Given this list of marker genes DPP4, FFAR1, SPCS2, ISL1, GIP, SEC11C, SPCS3, GATA4, PAX6, SPCS1, SEC11A, PCSK1, GPR119, here is a description of the gene set: part of: Incretin synthesis, secretion, and inactivation In K cells of the intestine the transcription factors PAX6 and PDX-1 activate transcription of the gene encoding Glucose-dependent Insulinotropic Polypeptide (GIP, first called Gastric Inhibitory Peptide). ProGIP is cleaved in secretory granules by Prohormone Convertase 1 (PC1) at 2 sites to yield mature GIP. In response to fat the GIP is secreted into the bloodstream. The half-life of GIP in the bloodstream is determined by Dipeptidyl Peptidase IV, which cleaves 2 amino acids at the amino terminus of GIP, rendering it biologically inactive. Reactome Pathway: Synthesis, secretion, and inactivation of Glucose-dependent Insulinotropic Polypeptide (GIP) species: Homo sapiens